Given this list of marker genes Arhgap44, Cplx1, Gripap1, Dbn1 (NCBI Gene Id 56320), Dag1, Zdhhc2, Stx7, Iqsec2, Map2k1, Itgb3, Tmem108, Gpc4, Nptn, Magi2, Itgb1, Prkcz, Camk2a, Tnik, Vps26b (VPS26 retromer complex component B), Cnih2, Rdx, Ghsr, Rap1a, Zdhhc3, Rapgef4, Neto2, Gpc6, Tyrobp, Kif2c, Gsk3b, Traf6, Cacna2d2, Ogt, Adam10, Nbea, Epb41l1, Hras, Kalrn, Gabarap, here is a description of the gene set: Mouse Gene Set: GOBP_REGULATION_OF_RECEPTOR_LOCALIZATION_TO_SYNAPSE Any process that modulates the frequency, rate or extent of receptor localization to synapse. species: Mus musculus